Given this list of marker genes Ikbkb, Vwf, Ctsh, Ptgdr2, Sfrp4, Fgf18, Drd3, Ncoa3, Epn2, Pdgfc, Tbc1d24, Mn1, Igf1r, Wnt1, Cracr2a, Sirt1, Prkcz, Fermt1 (NCBI Gene Id 241639), Rit2, Pkd2, Hap1 (NCBI Gene Id 268486), Scube1, Treml4, Pycard, Dlg5, Adamts20, Ccn2, Fga, Map2k6, Atf3, Vav3, Fnta, Tti1, Grem1, Prl3d3, Spin1, Adra1a, Lars1, Slc35c2, Pdpk1, Aldh1a3, Traf4, Stk19, Cxcl12, Sema3e, Pik3ca, Nox4 (NCBI Gene Id 50490), Ssh1, Gm12250, Ryk, Lep, Atoh8, Meis3 (Meis homeobox 3), Vegfb, Fgf23, Lats1 (NCBI Gene Id 16798), Bclaf1 (BCL2-associated transcription factor 1), Akr1c18, Daxx, Irs1, Jak1, Rapgef1, Ripk2, Spred2, Rpl23 (NCBI Gene Id 80497), Mrap, Plekha4, Gdf15, Alkal1, Tnks (NCBI Gene Id 97475), Psen1, Tnks2, Lck, Gadd45a, Arrb1, Clu, Bid, Fis1, Rgl2, Cdh13, Mos, Itgb3 (integrin beta 3), Mup5, Braf, Birc2 (NCBI Gene Id 77616), Ube2n, Sharpin, Tlr8, F2r, Lamtor5, Tm9sf5, Ptpn11, Sppl3, Cd27, Rad9a, Potefam3b, Jcad, Wdr24, Abca7, Htr2b, Nrg1, Gnai2, Prl8a1, Acvr1b, Specc1l (NCBI Gene Id 75003), Ifng, Amh, Adcyap1r1, Gipr, Pip4p1, Pik3cg, Poglut1, Prr5l, Znrf1 (zinc and ring finger 1), Gdf2, Casr, Xdh, Hgf, Ppm1n, Myoc (myocilin), Gpr4, Faf1, Abl1, Sema4c, Cradd, Fzd5, Spred1, Msx2, Rraga, Prrx1, Csnk1e, Cspg4, Incenp, Mmd2 (monocyte to macrophage differentiation-associated 2), Prkd2, Btbd10, Adora1, Nckap1l, Fgf5, Tcf7l2, Mir205, Hip1r, Tespa1, Sct, Ep300, P2rx7, Plcg2, Igfbp6, Lama2, Mtdh, Il5, Axl, Avpr2, Il4, Tnfrsf19, Prl8a9, Ripk3, Col3a1, Atm (NCBI Gene Id 77416), Gpr37, Rc3h2, Adrb1, Xbp1, Pmaip1, Guca1a, Cdkn2a, Prkca, Unc5b, Gipc1, Acvrl1, Prl3d2, Irak4, Rragb (Ras-related GTP binding B), Ddit3, Pde6h, Ppp3r1, Ccdc134, Gpr137c, Wnt4, Litaf, Ankrd66, Lama1 (laminin, alpha 1), Klk1b4, Pagr1a, Siah1a, Gpr27, Ptk7, Fadd, Ccdc22, Pik3r1, Slc19a1, Prkcd, Bmper, Abl2, Mmp8, Nup62, Il1r1, Il11, Rspo1, Reck, Adipoq, Lrrc19 (NCBI Gene Id 100410), Epgn, Dok5, Cntf, Esr2, Adra2b, Ccr2, Ccl19-ps5, Sdcbp, Lpar3, Gapdh, Slc9a1, Adra2a, Ddr1, Gapdhrt2, Mios, Prkra, Mid2, Lrg1, Tpr, Nedd4, Enho, Gucy1a1, Slc15a3, Crlf3, Scube3, Slc39a14, Rc3h1, Rasgrf1, Tmem108, Reln, Steap3, Trpm4, Thrb, Mup2, Gh, Uchl5, Siah1b, Gpc5, Mup4, Bmp2, Iqgap3, Tlr1, Cdh2, Alox12, Smarca4, Prr5 (NCBI Gene Id 97963), Calr, Mapk8ip2, C3, Prl3b1 (NCBI Gene Id 18776), Bmf, Lhcgr, Fgf7, Lrrk1, Lats2, Cd8a, Rock1, Mup11, Gadd45b, Raf1, Rnf146, Smarcb1, Hexim1, Taok3, Gper1, Fgf17, Unc13a, S100a7l2, Ninj1, Spatc1l, Prl2c2, Pde5a, Magi3, Tsc22d1, Trim39, Tgm2, Gpx1, Jak3, Ins2 (NCBI Gene Id 16334), Nenf, Bnip2, Otud7b, Usp50, Psap, Adrb2, Cul3, Rnf31, Slc30a10, Prl7a1 (prolactin family 7, subfamily a, member 1), Nppc, Slc38a9, Ccar2, Edn1, Hfe, Slc15a4, Fgb, Myorg, Itga1, Cux2, C1qtnf1, Dvl3, Fgd2, Prl3d1, Spin4, Ubr2 (NCBI Gene Id 99387), P2rx4, Kdr, Prkce, Cd300lf, Dync1li1, Skp2, Grp, Zbp1, Gpr137, Gpc3, Crlf2, Plxnb1, Rps20, Gpr39, Kcnn4, Il20ra, Foxa1, Malt1, Rpl26, Ar, Dusp15 (NCBI Gene Id 99102), Tspan5, Egfr, Ceacam1, Htra2, Wnk1, Foxa2, Prl7b1, Ncoa2, Cd3e, Tnik, Mllt3, Mbd2, Itgb1, Nup93, Icam1, Sulf1, Pcp4, Gucy1a2, Fasl, Ins1, Mgat5, Rragd, Irf7 (NCBI Gene Id 54123), Btk, Ppp2r3a, Arhgap8, Rsad2, Cdca8, Frmd6, Dennd2b, Ppp3cc, Mat2a, Ltbr, Tyro3, Rictor, Agr2 (NCBI Gene Id 23795), Ccl19-ps4, Angpt1, Map2k3, Ppm1a, Ptk2b, Gata3, Pdcl, Hint1, Mcf2l, Tial1, Crb2, Gab1, Mbip, Cyp27b1, Flot2, Frs2, Map4k4, Spi1, Tradd, Cdk5rap3, Sorl1, Lgr4, Foxp1, Trim30b, Ptbp1, Camk2b, Zap70, Sall1, Septin4, Ccdc88a, Phip, Tspyl5, Camk2a, Sting1, Asb15, Adissp, Brd4, Plaur, Rpl37, Hes5, Terf2ip, Gps2, Gfral, Card10 (NCBI Gene Id 105844), Cav2, Osm, Ikbkg, Adam17, Madd, L1cam, Fgf8, Acvr1, Irf3, Prdx2, Mif, Il18r1, Smpd3, Tbk1, Kmt2d, Ctsc, Nlgn2, Prkd1, Wnt5a, Cd180, Grin1, Cd74, Sbno1, Ccn1, Nkx3-1, Casp4, Gapdh-ps15, Hhex, Ctbp2, Fgf22, Axin1, Fer, Abra, Myocd, Tgfbr3, Traf7, Igsf11, Tspan14, Jmjd8, Htt, Usp32, Map2k4, Ei24, Sh3rf1, Hmgcr (3-hydroxy-3-methylglutaryl-Coenzyme A reductase), Ppp3r2, Adra1b, Lmcd1, Selp, Lrp4, Sstr4, Rxra, Ltb, Cdh3, Akr1b1, Prdm15, Pde8b, Sesn2, Pdgfb, Akt3, Egf, Pdgfd, Tcim, Elapor2, Mas1, Prok1, Yap1, Npsr1, Igf2, Bmp2k, Gas6, Rell1, Gskip, Ccl19-ps3, Foxd1, Ube2i, Loxl3, Esr1, Usp8, Csnk1g1, Lurap1l, Nmnat1, Csnk2b, Jag2, Tlr7, Adam9, Ltk, Hif1a, Sfrp2, Trim26, Rela, Mc1r, Gsk3b, Fgf20, Usp29, Castor1, Lgr6, Sik3, Htr6, Kank1, Crhr1, Prl5a1, Rasgrp1, Shkbp1, Rapgef2, Mlst8, Zdhhc5, Lmo3, Arrb2 (NCBI Gene Id 216869), Ttc21b, Gata5, Cd84, Got1, Nagk, Trim55, Il7, Fam110c, Ago3, Mul1, Akap12, Avpi1, Tab2, Depdc1b, Schip1, Adora2b, Grin2a, Pik3cb, Cyld, Mcl1, Taok2, Zfp622, Pafah1b1, Arhgef3, Ankrd17, Trim8, Fgfbp3, Txndc15, Camta1, Trim52, Prmt5, Golph3, C1qbp, Pik3ap1, Extl3, Ubr5, Ing4, Prl7d1, Il19 (interleukin 19), Trpv4, Notch2, Nptn, D1Pas1, Fgf9, Msx1, Irs2, Ntrk3, Psen2, Ppp2ca, Nox1, Drd5, Srarp, Klf2, Htr2c, Zeb2, Flt1, Cflar, Eng, Rala (NCBI Gene Id 80577), Rheb, Rap1a (NCBI Gene Id 99734), Trip6, Myh9, Stk4, Gcg, Rbx1-ps, Trim30d (tripartite motif-containing 30D), Prl3c1, Trim5, Jund, Pink1, Flt4, Bcl2l11, Gdf5, C1qtnf12, Lamtor4, Adcy10, Kiss1, Osbpl8, Notch1, Sh3rf2 (SH3 domain containing ring finger 2), Irs3, Sphk1, Sox2, Ikbke, Nampt, Zfp385a, Nlrp3, F11r, Gas8, Crkl, Sfpq, Baiap2, Hand2, Csf3, Fabp5, Alkal2 (ALK and LTK ligand 2), Hip1, Adipor1, Tnfrsf12a, Gpr3, Inca1, Cacnb3, Neurod2, Adrm1, Usp47, Nck1, Hes1, Dll4, Vav1, Dnajc27, Tnfaip3, Cul1, Macf1, Usp34, Atp6ap2, Fgf21 (fibroblast growth factor 21), Ccl21d, Grm2, Daam2 (dishevelled associated activator of morphogenesis 2), Vegfa, Brcc3dc, Sorbs1, Intu, Fkbp8, Cib1, Trim3, Prox1, Slc39a10, Rnf220, Wdr48, Nlgn3, Pih1d1, Hbegf, Zc3h3, Dync2h1, Cbl, Faim, Fgr, Bcap31, Ube2k, Rasgef1a, Dkk1, Lamb1, Lepr, Nlk, Mark4, Vsir, Tns3, Brcc3, Ly86, Gdf6, Grip2, Crh, Tab3, Ank3, Stx1b, Gpr55 (NCBI Gene Id 631726), Gpbar1, Fermt2, Rbx1, Ptpn1, Cx3cr1, Vcp, Ppp2r1a, Tnfrsf1a, Naip1, Gdf11, Cx3cl1, Trem2, Ttc23, Lrrk2, Naip2, Irgm2, Acp3, Wnk2, Nck2, Dapk3, Wnt11, Mturn (NCBI Gene Id 68235), Ghrh, Rab29, Asxl1, Nkd1, Grm1, Sox4, Mapk8ip3, Nrxn1, Dynlt1a, Ednrb, Tslp, Trim6, Robo2, Card11 (caspase recruitment domain family, member 11), Fgfr2, F7, Ddx1, Mrap2, Fgfr1, Fgg, Nts, Ifi211, Neo1, Jag1, Sh2d1b1, Wnt7a, Rap1b, Fgf6, Il7r, Igf1, Usp27x, Ndrg4, Sod1, Tlr9, Arrdc3, Il1b, Itgal, Serinc3, Nfat5, Lin28a, Ddx5, Sfrp1, Chd5, Itgb1bp1, Cherp, Lrch4, Rspo4, Alox15, Pla2g2a, Taar1, Nek10, Rtn4r, Crhr2, Alpk1, Mup3, Ghsr, Ksr2 (kinase suppressor of ras 2), Igfbp5, Trim32, Cdkn2b, Csf1r, Ccl5, Ankrd6, Mapk9, Bambi, Fgf2, Tpd52l1, Twsg1, Map3k3, Tert, Rbck1, Ntrk1, Csnk1d, Nfkb1, Cdon, Kras, Fbxw11 (NCBI Gene Id 72380), Acvr2b, Lef1, Tnfaip8l3, Cdkn1c, Prl2a1, Synj2bp, Rtn4, Scube2 (signal peptide, CUB domain, EGF-like 2), S100a9, Bmyc, Nacc2, Rps6kb1, Glce, Agap2, Tbl1x, Ddx60, Mfn2, Insl3, Apoe, Bmp4, Cass4, Arl6ip5, Pias4, Adgrv1, Sox11, Ndp, Spry2, S100a4, Tnfsf14, Tgfb3, Bad, Sos2, Ide, Csnk1g3, Tgfbr1, Rspo2, Htr2a, Necab2, Cxcr4, Afap1l2, Stk39, Agtr2, Ramp3, Peli1, Mad2l1, Gata6, Il6ra, Fzd10, Bmp10, Nqo2, Ada, Ccnq, Frmd7, Cd300ld3 (CD300 molecule like family member D3), S100b, Cenpj, Skil, Ccr1, Ubb, Ncs1, Cpne1, Cdc42, Cd4, Fgf15, Mef2c, Prl4a1, Crebbp, Spag9, Fgf10, Tlr4, Atf6, Akap13, Wnt3, Map3k12, Ngly1, Tmem100, Akap6, Atp2c1, Knl1, Znhit1, Cavin3, Rab34, Fzd7, Neu3, Slamf1, Trps1, Lamc1, Prl, Cd81, Eda2r, Xiap, Pea15a, Scimp, Phlpp1, Pcsk5, Dynlt1f, Ccr7, Ctns, Ppard, Fpr-rs3, Oprk1, Skor2, Rims2, Pdgfa, Hpse, Opa1, Sema4d, Serpinf2, Lancl2, Dusp19, Mmp9, Klhdc10, Cmtm3, Pdia3, Tbl1xr1, Gsdma3, Ift88, Disc1, Pomc, Dvl1, App, Ndst1, Usp4, Glipr2, Sorbs3, Eif2a, P2ry1, Nfam1, Erbb3, Clec4n, Bmal1, Tek, Tgfb1i1, Cdh5, F3, Prpf4b, Dok7 (docking protein 7), Drd4, Lamtor2, Dab2, Adora2a, Trim30c, Calm1, Ccl21e, Ppp3cb, Lat, Bag4, Mid1, Irak1bp1, Cd36, Prkar1b, Fas, Pum2, Crebrf, Cyfip1, Prag1, Ark2c (NCBI Gene Id 72870), Pros1 (NCBI Gene Id 19128), Zranb1, Dsc2, Zbed3, Dbn1, Rxfp2, Acta2, Wnt7b, Rnf185 (ring finger protein 185), Nr1h3, Gpr137b, Zbtb7b, Tgfbr2, Rragc, Iqschfp, Myc, Map3k13, Nek7, Bank1, Mir494, Gpr183, Ticam2, Il1a, Jun, Grin2c, Gsdme, Chp2, Men1, Bmpr1a, Fzd8, Erp29, Acvr2a, Numa1, Il6st, Gpr101, Gfi1, Cd19, Usp15, Gprc5b, Crk, Nmur1, Wdr59, Fpr-rs4, Nf1, Tenm1, Bdnf, Trp53, Ctnnb1, Fbxl15, Ror2, Mertk, Chsy1, Tnf, Tsc2, Mfng, Lfng, Ncam1, Eif2ak2, Rnf167, Adcyap1, Agrn, Igfbp3, Runx3, Prnp, Klhl22, Aspm, Pla2r1, Erbb2, Gria1, Cdc73, Usp17le, Adamts3, Gli1, Npr1, Med1 (NCBI Gene Id 19014), Trim25, Nrp1, Dgki, Tnfsf10, Cd40, Prl3a1, Esm1, Pebp1, Stambpl1, F2rl1, Tmem33 (transmembrane protein 33), Pdcd10, Rnf111, Gdi1, Smad4, Sec13, Ngf, P2ry6, Itm2c, Tank, Map4k1, Cntn2, Itga5, Pde8a, Itga8, Styxl1 (serine/threonine/tyrosine interacting-like 1), Dhh, Cyba, Prkch, Pdcd7, Gbp2, Naip6, Ccdc88c, Smo, Ccl21a, Npnt, Pde6g, Il10rb, Lurap1, Trp73, Dgkd, Lims1, Gsk3a, Unc5cl, Nectin2, Vdr, Sema7a, Dvl2, Gucy2d, Cd14, Clec16a, Cyct, Adora3, Ksr1, Grm5, Mavs (NCBI Gene Id 228607), Drd1, Fn1, Csnk1g2, Maged1, Traf6, Usp46, Inhbb, Nrarp, Prl6a1, Stap1, Adgrg1 (NCBI Gene Id 56037), Ccl19-ps1, Asb3, Ccl19-ps6, Mydgf, Lsm14a, Edn2, Prrx2, Ezh2, Pth, Ccl21f, Calm3, Snx5, Ing2 (inhibitor of growth family, member 2), Edar, Nherf1, Taok1, P2ry12, Grk2, Prl8a2, Lta (NCBI Gene Id 16992), Tnfrsf11a, Igtp, Rasd2, Gcnt2, Gip, Cnot9, Rps12, Usp1, Tyk2, Ackr3, Cxcl17, Tgfb1, Trim41, Maz, Itgav, Pim2, Rnf13, Pdgfrb, Irak1, Cyfip2, Flot1, Lpar1, Arfgef1, Ngfr, Parp1, Cysltr2, C1qtnf2, Ptpn2, Pten, Tlr3, Col1a1, Itsn1, Havcr2, Trim56, F10, Bax, Tnfsf15, Dusp22, Negr1, Lipa, Nodal, Ighm, Dhx36, Pja2, Grm4, Tedc1 (tubulin epsilon and delta complex 1), Synpo2l (NCBI Gene Id 68760), Mmp12, Rpl11, Rgs4, Nlgn1, D130043K22Rik, Nlrp6, Sema5a, Pibf1 (NCBI Gene Id 75821), Ptprc, Park7, Dab2ip, Map3k5, Ptger4, Mt3, Pak2, Dock2, Ptger3, Spop, Map2k7, Eda (NCBI Gene Id 13607), S100a8, Becn1, Ppp1ca, Ctdnep1, Tmem198b, Erfe, Fgd4, Fbxw7, Wac, Rtkn2, Huwe1, Cav1, Gadd45g, Nucks1, Tirap (toll-interleukin 1 receptor (TIR) domain-containing adaptor protein), Wbp2, Map3k4, Fgf1, Cxcl5, Dact1, Prl7a2, Or2at4, Pim1, Fgf16, Lgals9, Adam8, Cd44, Fpr-rs7, Akt1, Apaf1, Cd86, Plpp3, Kcp, Smad2 (SMAD family member 2), Cd226, Rptor, Stmp1 (short transmembrane mitochondrial protein 1), Ppp2r5d, Lpar2, Trim12a, Fgfbp1, Ddx21, Rac1, Trim15, Nrk, Zmiz1, Pdgfra, Rspo3, Rwdd3, Thra, Mst1r (NCBI Gene Id 235603), Ucn, Il10ra (interleukin 10 receptor, alpha), Tgfa, Lamtor1, Lilra5, Ly96, Gpr62, Dhx15, Sco1, Lbx2, Il18, Cth, F2, Tmem9, Ifnb1, Ece1, Mfhas1, Ube2b, Il6 (NCBI Gene Id 16193), Fgf4, Prl2c5, Ccl3, Pla2g6, Ccn4, Hnf1a, Evc, Klf14 (NCBI Gene Id 676363), Zdhhc1, Clec4d, Crbn, Tifab, Slc46a2, Stra6, Afdn, Jrk, Trim30a, Prl2c1, Appl2, Lypd6, Tmem106a, Map3k7, Emp2, Lif, Shoc2, Il10, Rundc3a, Myd88, Ajuba, Erbb4, Bub1, Robo1, Epo (NCBI Gene Id 13856), Vnn1, Cibar1, Cited2, Fbh1, Net1, Stk36, Plagl2, Bbc3, Klk6, Wnt3a (NCBI Gene Id 22416), Laptm5, Bmpr1b, Thbs1, Ptk2, Ror1, Pbxip1, Tfrc, Fgfr3, Avpr1b, Cntn6, Nepro, Snw1, Prkcb, Ghrl, Txn1, Atp6v0c, Tbx20, Nupr1, Mbd5, Stat3, Map4k2, Caprin2, Arhgef5, Fyn, Ulk3, Dedd2, Npr2, Ifi204, Muc20, Stx1a, Ripk1, Hcrtr1, Inava, Npy, Ube2v1, Plscr1, Ywhae, Bmp5, Slc2a10, Pelo, Tmem198, Stard10, Zc3hav1, Traf2, Zdhhc3, Kif7, Gpnmb, Usp9x, Card9, Pak1, Irgm1, Tff2, Mapk8ip1, Ntsr2, Ffar4, Ret, Ppp5c, Tlr6, Aak1, Picalm, Ccl21b (C-C motif chemokine ligand 21B (leucine)), Drd2, Ctnna1, Epha8, Ptgis, Nlrp12, Seh1l, Prmt1, Sulf2, Aurkb, Bok, Flna, Dlx5, Tedc2, Gdf7, Ddr2, Ptpn6, Peg12, Akt2, Por, Mtor, Cartpt, Nppb, Tubd1, Alox8, Dhx33, Rps7, Flcn, Nelfe, Wnt5b, Gsx2, Hdac3, Gpr37l1, Adra1d (adrenergic receptor, alpha 1d), Rnf183, Akap5, Dlg4, Atp6v1c2, Rpl37rt, Marco, Isl1, Dixdc1, Hipk2, Ern1, Ltf, Pparg, Peli3, Peli2, Ccbe1 (NCBI Gene Id 71072), Pik3r6, Fnip2, Auts2 (NCBI Gene Id 72597), Agt, Armc9, Pik3r5, Casp8, Npy5r, Tbx1, Ift172, Coro7, Dcc, Pdcd4, Hcls1, Gsn, Lmnb1, Serpina12, Tpbg, Prlr, Cdk10, Ptpn22, Prl8a6, Asxl2, Mad1l1, Atr, Zdhhc9, Nfatc4, Marcks, Rps23rg1, Bak1, Il3, Dstyk (dual serine/threonine and tyrosine protein kinase), Ifi205, Nr1h4, Shox2, Hcst, Adnp, Bmp6, Gen1, Tmod2, Trim38, Cd24a, Klk5, Bcl2l14, Gorab, Ubd, Efna1, S100a13, Ralb (v-ral simian leukemia viral oncogene B), Ern2, Ctsd, Hspa1b, Eif2ak3, Ruvbl1, Insr, Pin1, C1qtnf4, Epor, Rock2, Fcer1a, Fgf3 (fibroblast growth factor 3), Taf6, Nod1, Dkk2, Mtch2, Pla2g5, Fzd9, Zswim2, Wdfy1, Grin2b, Kiss1r, Mapre2, Dcn, Prl8a8, Bcar3 (NCBI Gene Id 99553), Lamb2, Mapk8, Ptp4a3, Vtn, Dhx58 (NCBI Gene Id 93832), Ephb2 (Eph receptor B2), Otub1, Cdkn2aip, Tasl, Prl7c1, Birc7, Fam53b, Adrb3, Trat1, Wwc1, Ube2o, Thpo, Igfbp4 (insulin-like growth factor binding protein 4), Shank1, Rps15, Ppp3ca, Ntrk2, Srms, Stk11, Birc5, Dynlt1c, Timp2, Srpx, Nppa, Fpr-rs6, Hras, Maoa, Ppp2r5b (NCBI Gene Id 225849), Rxrb, Prl2b1, Plcb1, Amer1, Calm2, Ihh, Phb2, Tnfsf12, Map3k11, Smad3, Cd28, Bmp7, Adgra2, Eef1e1, Prl2c3, Pld2, Vav2, C1qtnf3, Nr3c2, Trim62, Nid1, Iapp, Parp14, Ticam1, Sh3glb1, Ilk, Ptprj, Ager, Itpkb, Lyn, Calcr, Fpr2, Traf5, Kl, Ndc80, Cat, Gapdhrt, Trim13 (NCBI Gene Id 66597), Mesp1 (NCBI Gene Id 17292), Map2k1, Edaradd (EDAR associated via death domain), Dynlt1b, Lbp, Wnt16, Wwox, Zfp423, Mink1, Rassf2, Rack1, Ambra1, Hsp90ab1, Trp63, Csf1, Hic1, Ghr, Nr3c1, Camk2d, Atat1, Otud5, Ogt, G0s2, Hpx, Ccn3, Oasl1, Dll1, Fam83b, Trim12c, Ube3a, Klb, Casp1, Adra2c, Sash1, Syk, Pin1rt1, Fxr1, Rbm47, Ago1, Gas1, Ppp2r1b, Furin, Chi3l1, Map3k1, Lamtor3, Ankrd1, Apoa1, Ccr1l1, Epha4, Ednra, Lrp1, Potefam3a, Traf3ip2, Nos1, Prkn, Trim44, Hax1, Nle1, Neto2, Jak2, Parp9, Stk25, Rell2, Bcl10, Shank3, Cyp1b1, Hyal2, Dnm1l, Stox1, Chga, Nmi, Xrcc3 (X-ray repair complementing defective repair in Chinese hamster cells 3), Tnfsf11, Ccl19, Met, Garem1, Mapkbp1, Fzd4 (NCBI Gene Id 14366), Wasf1, Siglec1, Oprm1, Nod2, Gas2l2, Casp2, Tmem132a, Shc1, Ascl1, Rhoa, Pml, Musk, Mal, Nlrc5, Neto1, Smoc2, Chuk, Chrna7, Smcr8, Ntf3, Grin2d, Rims1, Mapk3, Sh2b1, Kit (NCBI Gene Id 16590), Fnip1, Pum1, Card14, Edn3, Csnk2a1, Irak2, Ppp1r15a, Ddx3x, Actn4 (NCBI Gene Id 97354), Fshr, Map3k10, Sh3rf3, Src, 3425401B19Rik, Zc3h12a, Ifi35, Dok4, Apela, Rbpj, Lmx1a, Wnt10b, Iqgap1, Gata4, Tab1, Mup1, Tifa, Wnt9a, Gkap1, Scel, Cd40lg, Wls, Inhba, Slc2a4, Kitl, Vangl2, Hmgb1, Shq1, Csnk1a1, Lims2, Irak3, Usp12, Bmpr2, Cripto, Spring1, Tnip2, Sos1, Frat1 (NCBI Gene Id 14296), Lgr5 (NCBI Gene Id 14160), Car8, Phb1, Prxl2c, Gpr155, Gbp5, Bmt2, Nr2c1 (nuclear receptor subfamily 2, group C, member 1), Gid8, Cd63, Sctr, Il34, Txk (NCBI Gene Id 320533), Alox12b, Map3k20, Vps35, Stk3, Shh, Ppm1b, Grb10, Mesd, Tgfb2, Ppia, Fgfr4, Rfng, Ing5, Exoc4, Rps3, C5ar1, Tlr2, Klk14, Fcgr2b (NCBI Gene Id 98391), Rb1cc1, Paqr3 (NCBI Gene Id 70746), Mmp2, Pcid2, Aars1, Naip5, Clec7a, Zcchc3, here is a description of the gene set: studied in species Mus musculus Any process that activates or increases the frequency, rate or extent of signal transduction. Mouse Gene Set: GOBP_POSITIVE_REGULATION_OF_SIGNAL_TRANSDUCTION